The following is a description of a gene set: Loss of elasticity of the upper and lower eyelids causing the skin to sag and bulge. species: Homo sapiens Dermatochalasis Human Gene Set: HP_DERMATOCHALASIS, and this is the list of marker genes: ARL6, CCDC28B, SMC3, COL5A1, COL1A1, PIK3CD, EFEMP2 (NCBI Gene Id 30008), LTBP1, FBLN5, BBS1, COL5A2, KNSTRN